The following is a description of a gene set: Human Gene Set: GOBP_ER_OVERLOAD_RESPONSE The series of molecular signals initiated by the accumulation of normal or misfolded proteins in the endoplasmic reticulum and leading to activation of transcription by NF-kappaB. studied in species Homo sapiens, and this is the list of marker genes: ATG10, EIF2AK3 (NCBI Gene Id 9451), TP53, SELENOS, GSK3B, TMCO1, HSPA5, PPP1R15B, WFS1, DDIT3, CCDC47